Given this list of marker genes STYK1, ALG2, AKT1, STXBP4, SLC25A18, LHX3, CAMK2B, here is a description of the gene set: Human Gene Set: MIR4740_3P from publication Chen Y, Wang X (PMID 31504780) studied in species Homo sapiens Genes predicted to be targets of miRBase v22 microRNA hsa-miR-4740-3p in miRDB v6.0 with MirTarget v4 prediction scores > 80 (high confidence targets).